The following is a description of a gene set: studied in species Homo sapiens Human Gene Set: REACTOME_RHOD_GTPASE_CYCLE RHOD GTPase cycle, and this is the list of marker genes: RACGAP1 (NCBI Gene Id 94651), MCAM, LMAN1, PIK3R1, CAV1, ACTN1, ARHGAP35, ARHGAP21, VAPB, LEMD3, STBD1, MOSPD2, VRK2, TOR1AIP1, STEAP3, FILIP1, ESYT1, RAB7A, PLXNB1, EMD, PGRMC2, ARHGAP32, RHOD, CAPZB, ARHGAP5, ARHGAP17, LBR, ARHGAP12, DIAPH3, DEPDC1B, VAMP3, EFHD2 (NCBI Gene Id 79453), PAK5, AKAP12, ANKFY1, VANGL1, HINT2, ARHGAP1, SLC4A7, ARHGAP26, DIAPH1, WHAMM, PIK3R2, PAK6, ADD3, ARHGAP39, PLXNA1, DIAPH2, DBN1, TMPO, GOLGA8R, CPNE8, LMNB1